Given this list of marker genes EXOSC3, D2HGDH, EXOSC9, SLC52A3, NFASC, MIR140 (NCBI Gene Id 406932), IGHMBP2, AGTPBP1, SCN4A, EXOSC8, SLC25A46, VRK1, SCO2, SERPING1, PLP1, KIF22, here is a description of the gene set: species: Homo sapiens Human Gene Set: HP_INSPIRATORY_STRIDOR Inspiratory stridor Inspiratory stridor is a high pitched sound upon inspiration that is generally related to laryngeal abnormalities.